The following is a description of a gene set: Genes up-regulated in LSK cells (bone marrow) as a function of a QTL for the size of hematopoietic stem cell (HSC) population: comparison of congenic B.D. chr3 (BD, large HSC size) vs parental B6 strain (tiny HSC size). from publication Liang Y, Jansen M, Aronow B, Geiger H, Van Zant G (PMID 17220891) studied in species Mus musculus Human Gene Set: LIANG_HEMATOPOIESIS_STEM_CELL_NUMBER_LARGE_VS_TINY_UP We mapped quantitative trait loci that accounted for the variation in hematopoietic stem cell (HSC) numbers between young adult C57BL/6 (B6) and DBA/2 (D2) mice. In reciprocal chromosome 3 congenic mice, introgressed D2 alleles increased HSC numbers owing to enhanced proliferation and self-renewal and reduced apoptosis, whereas B6 alleles had the opposite effects. Using oligonucleotide arrays, real-time PCR and protein blots, we identified latexin (Lxn), a gene whose differential transcription and expression was associated with the allelic differences. Expression was inversely correlated with the number of HSCs; therefore, ectopic expression of Lxn using a retroviral vector decreased stem cell population size. We identified clusters of SNPs upstream of the Lxn transcriptional start site, at least two of which are associated with potential binding sites for transcription factors regulating stem cells. Thus, promoter polymorphisms between the B6 and D2 alleles may affect Lxn gene expression and consequently influence the population size of hematopoietic stem cells., and this is the list of marker genes: ITGB1BP1, LTV1 (LTV1 ribosome biogenesis factor), ST6GALNAC4, SLFN12, TMEM183A, GNB4, NLRX1, CDKN3, TMEM141, FKBP1A, GTF3A, ARHGAP9, S100A6, DIO2, FCER1A, GCAT, FADS1, F2RL3, LYZ, PTTG1, RASGRP2, SMIM7, FKBP11, PGAM1, TUBA1A, HSPA4, HLA-DMB, GNG12, PRTN3, SARAF, GBA1, SERPINE2, ICAM2, IL1R1, ELOVL2, MSR1, JKAMP, MANF, BEX4, LRRN1, TLR6